The following is a description of a gene set: Human Gene Set: GOMF_DIOXYGENASE_ACTIVITY species: Homo sapiens Catalysis of an oxidation-reduction (redox) reaction in which both atoms of oxygen from one molecule of O2 are incorporated into the (reduced) product(s) of the reaction. The two atoms of oxygen may be distributed between two different products., and this is the list of marker genes: CDO1, KDM2A, KDM3A (lysine demethylase 3A), TET3, RIOX1, PLOD1, ADI1, P3H3, PLOD3, PIR, P4HB, ALKBH5, P4HA1, ASPHD1 (aspartate beta-hydroxylase domain containing 1), JMJD1C, RSBN1, HPD, P3H1, HIF1AN, HSPBAP1, KDM4B, HGD, EGLN1, TET1, P4HA3, ALOX5, KDM7A, JMJD6, TYW5, BCO1, BBOX1, TET2, PLOD2, IDO1, RPE65, EGLN3, KDM3B, ALKBH4, P4HA2, ALOXE3, KDM5D, POR, P4HTM, PHYH, BCO2, ALKBH7, PHYHD1, FTO, KDM5C, HPDL, OGFOD2, ASPH, KDM6A, ALOX12, ADO, JMJD7, ALKBH3, ETHE1, PHF2, KDM4E, IDO2 (indoleamine 2,3-dioxygenase 2), PTGS2, OGFOD1, ALKBH2, ALKBH8, TMLHE, KDM4C, HAAO, PHF8, KDM4A, ALOX12B, UTY, ALKBH1, ALKBH6, KDM2B, P3H2, KDM4D, ASPHD2, HR, KDM8, RIOX2, JMJD4, ALOX15, TDO2, KDM5A, OGFOD3, RSBN1L, KDM5B, ALOX15B, EGLN2, KDM6B, PTGS1